Given this list of marker genes CCNG1 (NCBI Gene Id 900), COX6C, TMEM267, SIGLEC6, BSCL2, NIPSNAP1, CYP1B1, PSMD1, TUBB (tubulin beta class I), PFAS, MGST3 (microsomal glutathione S-transferase 3), BTN2A2, DERA, MAB21L1, RAN, SEMA4C, ATP8B4, TCEAL9, DDRGK1, RNF187, FAM216A, CRTAP, RABGGTB, KCTD7, EIF3M, PNMA1, UBE4B, VDAC2, ASNS, OPTN, BEX4, SHMT2, VANGL1, ITFG1, ERCC2, DCAF6, AIMP2, GBA1LP, MAST4, CLDN6, RPS13, CBLB, CTSH, PCNA, MRPL4, NDUFA9, EIF2B5, RRM1, DTWD1, CCT5, AP2A2, WT1, ELAVL1, PARN, GALNT2, PCCA, VDAC3, POLR2I, NR0B1, HTATSF1, IARS2, CBX5, DET1, RPN2, CHCHD2, CSNK2A2, DHRS3, RC3H2, SELENOP, DAP3, CCDC68, RERE, INTS7, UMPS, RYBP, RPL26, TMEM185B, FBL, SYNE3 (spectrin repeat containing nuclear envelope family member 3), ATP6V0E2, ZNHIT6, WDR11, UTP3, CMA1, GIMAP6, CSE1L, SQLE, UQCRC2, NELFA, MRPL34, PSMA3, CAMLG, ATRAID, RPF1, CSTPP1, SETMAR, MCUR1, MEIS2, GRN, MDH1, SLC25A6, CAST, CDK18, BST1, LMAN2L, GATB, E2F8 (NCBI Gene Id 79733), GRSF1, CLASP1 (cytoplasmic linker associated protein 1), ABCF2, VAT1, APC, RXYLT1, PSMD6, PHB1, PPIA, SMARCC1, SKIC3, SLC5A3, BABAM2, MAP2, MRPL16, MFSD13A, SOX4, GNPDA1, FAM171A1, GSTT2, NHP2, AKR1B1, HSPA8, HSD17B12, SPARC, GZMB, CCT8, STOML2, AGPAT5, DPH2, JUN, N6AMT1, MCM3, COPS6, GMPR, HSPE1, CLNS1A, ZMYND8, GORASP2, AMHR2, CHI3L1, IPO7, RPL4, TRIAP1, AKR7A2, TMEM268, DNMT1, SEPTIN8, RPL36, NDUFB4, TRAM1, RTL8C, NDUFA7, SORBS1 (sorbin and SH3 domain containing 1), CANX, SLC39A14, EGR1, EGLN3, CEBPG, ABCD4, APIP, MFAP3L, PDHX, DPYD, DNAJC15, HMG20A, ALDH1A1, LSM5 (NCBI Gene Id 95999), RANGRF, NDUFA5, ENO1, TTC27, ANKRD17, CHN2, PJA1, NLE1, NDUFAF3, PRMT5, MRPL23, RPS4X, LAX1, SSBP1, MANF, MAGEB4, YBX3, RPA1, ATP5PF, ZFYVE21, TUBB3, DPAGT1, AIMP1, here is a description of the gene set: from publication Jeffrey KL, Brummer T, Rolph MS, Liu SM, Callejas NA, Grumont RJ, Gillieron C, Mackay F, Grey S, Camps M, Rommel C, Gerondakis SD, Mackay CR (PMID 16474395) species: Homo sapiens Genes down-regulated in comparison of eosinophils versus mast cells. In the present study we used Affymetrix oligonucleotide microarrays to produce gene transcription profiles for the major leukocyte types in humans. This comprehensive dataset enabled us to not only establish which genes were expressed in each leukocyte type, but also which genes were expressed in each subset after activation. The used of a comprehensive dataset of gene profiles from all the major human leukocyte subsets enabled a novel and powerful means for identification of genes associated with single leukocyte subsets, or different immune paradigms. Human Gene Set: GSE3982_EOSINOPHIL_VS_MAST_CELL_DN